The following is a description of a gene set: Mouse Gene Set: WP_GLUTATHIONE_AND_ONECARBON_METABOLISM species: Mus musculus Glutathione and one-carbon metabolism, and this is the list of marker genes: Gss, Mtrr, Shmt2, Mat1a, Dnmt3a, Ggt5, Shmt1, Amt, Idh1, Gpx2, Ahcy, Mat2b, G6pdx, Mtr, Cbs, Gpx4, Gpx3, Ahcyl2, Chdh, Oplah, Cth, Dnmt1, Mthfr, Bhmt, Gpx1, Gclm, Ggt1, Anpep, Gsr, Gclc, Dnmt3b